Given this list of marker genes Btg2, Junb, Chd3, Mxd4, Rflnb, Satb1, Fyb1 (FYN binding protein 1), here is a description of the gene set: species: Mus musculus Mouse Gene Set: CUI_T_CELL_CD4_IFNG_RESPONSE_DN Genes negatively differentially expressed in cell type: CD4+ T cell upon treatment with cytokine: IFN-γ in mouse lymph nodes in vivo. from publication Cui A, Huang T, Li S, Ma A, Pérez JL, Sander C, Keskin DB, Wu CJ, Fraenkel E, Hacohen N (PMID 38057668) Cytokines mediate cell-cell communication in the immune system and represent important therapeutic targets. A myriad of studies have highlighted their central role in immune function, yet we lack a global view of the cellular responses of each immune cell type to each cytokine. To address this gap, the authors created the Immune Dictionary, a compendium of single-cell transcriptomic profiles of more than 17 immune cell types in response to each of 86 cytokines (>1,400 cytokine-cell type combinations) in mouse lymph nodes in vivo. A cytokine-centric view of the dictionary revealed that most cytokines induce highly cell-type-specific responses. For example, the inflammatory cytokine interleukin-1β induces distinct gene programmes in almost every cell type. A cell-type-centric view of the dictionary identified more than 66 cytokine-driven cellular polarization states across immune cell types, including previously uncharacterized states such as an interleukin-18-induced polyfunctional natural killer cell state.